Given this list of marker genes JAG2, ATOH1, RBPJ, NOTCH1, ESRP1, here is a description of the gene set: The process in which a cell becomes committed to become an inner ear receptor cell. Human Gene Set: GOBP_INNER_EAR_RECEPTOR_CELL_FATE_COMMITMENT species: Homo sapiens